The following is a description of a gene set: Reactome Pathway: Recognition and association of DNA glycosylase with site containing an affected purine The recognition and removal of an altered base by a DNA glycosylase is thought to involve the diffusion of the enzyme along the minor grove of the DNA molecule. The enzyme presumably compresses the backbone of the affected DNA strand at the site of damage. This compression is thought to result in an outward rotation of the damaged residue into a "pocket" of the enzyme that recognizes and cleaves the altered base from the backbone. studied in species Homo sapiens part of: Depurination, and this is the list of marker genes: H2AC7, H2AC4, H3-4, H2BC17, POT1, H2BC13, H2BC11, H2BC5, H2BC4, H2BC26, H2BC15, H2AC14, H2BC3, ACD, H2BC9, H2AC20, H2BC12L, TERF1, TINF2, MPG (N-methylpurine DNA glycosylase), TERF2 (NCBI Gene Id 7014), H2AZ2, MUTYH, H2AJ, H2BC12, H2AC18, TERF2IP, H2AX, NEIL3, H2BC14, OGG1, H2AC6, H2BC1, H2AB1, H4C1, H2BC21